The following is a description of a gene set: A G protein-coupled receptor activity that is activated by cleavage by a serine protease, exposing a tethered ligand corresponding to the new N-terminus, which binds to the receptor and activates it. Human Gene Set: GOMF_PROTEINASE_ACTIVATED_RECEPTOR_ACTIVITY studied in species Homo sapiens, and this is the list of marker genes: F2R, F2RL1, GP1BA, F2RL2, F2RL3